The following is a description of a gene set: Abnormality of ocular abduction An abnormality involving the movement of the eye outwards. Human Gene Set: HP_ABNORMALITY_OF_OCULAR_ABDUCTION studied in species Homo sapiens, and this is the list of marker genes: MYMK, TUBB3, TUBA1A, TUBB2B, ROBO3, MAFB, KIF21A, CHN1, MYMX, PHOX2A, SALL4, COL25A1, GRM1